Given this list of marker genes APIP, GOT1 (glutamic-oxaloacetic transaminase 1), MRI1, ENOPH1, ADI1, MTAP, here is a description of the gene set: studied in species Homo sapiens Human Gene Set: REACTOME_METHIONINE_SALVAGE_PATHWAY Methionine salvage pathway